The following is a description of a gene set: Human Gene Set: GSE3982_BASOPHIL_VS_CENT_MEMORY_CD4_TCELL_UP from publication Jeffrey KL, Brummer T, Rolph MS, Liu SM, Callejas NA, Grumont RJ, Gillieron C, Mackay F, Grey S, Camps M, Rommel C, Gerondakis SD, Mackay CR (PMID 16474395) In the present study we used Affymetrix oligonucleotide microarrays to produce gene transcription profiles for the major leukocyte types in humans. This comprehensive dataset enabled us to not only establish which genes were expressed in each leukocyte type, but also which genes were expressed in each subset after activation. The used of a comprehensive dataset of gene profiles from all the major human leukocyte subsets enabled a novel and powerful means for identification of genes associated with single leukocyte subsets, or different immune paradigms. species: Homo sapiens Genes up-regulated in comparison of basophils versus central memory CD4 T cells., and this is the list of marker genes: BASP1, ZNF106, EVI2B, SF3B1, LMO2, P2RY14, AZI2, ANKRD27, FLI1, PRNP, SQSTM1, KRT81, H3C2, TALDO1, LSM3, ATP10D, GSN, FRY, PCSK1, LAT2, NDUFV2, AATK, HDC (NCBI Gene Id 3067), MXD1, OPN3, KDM5B, DPY19L1, CRNKL1, LBHD1, ZMIZ1, PSME1, GSE1, IFITM2, TAF9, RNF10, SUPT4H1, BACE2, BRD7, PTPRE, SMC4, NCF4, CD19, ANXA1, GPR65, MGAM, KIT, BACH1, ATP5MG, SEC23B, ZDHHC3, IK, CACNA1E, DPEP2, SAP30L, SH3GLB1, ITPRID2, RHOQ, NXF2, CDK19, CSF1, SLC2A10, MILR1, PERP, VCL, KBTBD11, BST1, PSEN1, CREG1, AREG, VPS8, CD33, CDK7, PPP2R5A, H2BC12 (NCBI Gene Id 85236), YES1, CAV2, PTP4A1, PDGFC, MAPK14, PTPN12, GSK3B, HTRA2, TREM2, CHD7, TM9SF2, STX7, MAN1A1, HGF, VAV3, FAM30A, PSTPIP2, ZFYVE16, ELOB, CHPT1, RREB1, ADGRE2, XRCC1, ESYT1, ADGRE1, WDR46, CLK4 (NCBI Gene Id 57396), ALDH2, RIOK3, SH2B3, BAG1, HHEX, HSD17B4, BTK, KDM6A, LYZ, NSF, WASHC4, SOS2, TUBB3, HLA-B, CTNNBL1, FAM3A, MTARC1, CYB5R4, YWHAZ, FAM124B, RNF130, ZDHHC7, OSER1, MIA, CEP63, MANF, RALB, C22orf46P, ZSCAN16, OSGIN2, ASL, KBTBD2, ARPC3, TXNRD1, PPP4R1, WWC3, SWAP70, GIT2, H3-3B, TLE4, ABHD5, CDA, RB1CC1, SF3B5, DNTT, CD300A, MAP1LC3B, TRIP4, PELI1, GALC, RNASE2, TM6SF1, C1RL, LMBRD1, DRAM1, DHX15, SERPINB1, PDCD4-AS1, DCTN3, BAZ2B, MYB, FNBP1L, HBP1, CDIP1, NOP10, SERINC1, COX8A, BCAR3, PLAGL1, RRAGD, PLCG2, TLR8, ATP5MF, ATP5ME, MARCHF2, TIMM8B, RUFY1, SVIL, RUSC2, TENM4, CHP1, HRH4, LUZP1 (leucine zipper protein 1), TRIM37, NRDC (NCBI Gene Id 4898), ACOX1, ZNHIT1, PECAM1, DAZAP2, GABARAP, PLAA, RHOA, SLC44A1, HEXIM1, CLINT1, VEZF1, FAM32A, BTN2A1, RASGRP3